The following is a description of a gene set: A protein complex that constitutes a specific site of protein translocation across the endoplasmic reticulum, which involves the signal recognition particle receptor. The complex contains a core heterotrimer of alpha, beta and gamma subunits, and may contain additional proteins. studied in species Mus musculus Mouse Gene Set: GOCC_TRANSLOCON_COMPLEX, and this is the list of marker genes: Ssr4, Arl6ip1, Sec61b (NCBI Gene Id 66212), Sec61g, Sec61a1 (SEC61 translocon subunit alpha 1), Sec61a2